The following is a description of a gene set: Diseases of carbohydrate metabolism studied in species Homo sapiens Human Gene Set: REACTOME_DISEASES_OF_CARBOHYDRATE_METABOLISM, and this is the list of marker genes: G6PC3, KHK, LCT, GAA, SI, UBA52, GUSB, UBB, PPP1R3C (NCBI Gene Id 5507), GNS, NAGLU, SLC37A4, GYG1, GBE1, GYS2, EPM2A, RPIA, TALDO1, IDS, GYS1 (glycogen synthase 1), HYAL1, HGSNAT, DCXR, GLB1, NHLRC1, IDUA, G6PC1, GALNS, GYG2, ALDOB, SGSH, UBC, RPS27A, ARSB